Given this list of marker genes HOMER2, IL1A, XCL1, GATA3, CLEC7A, TRIM27, RIPK2, HDAC7, PTPRC, IRF4, FOXP3, CD28, LAPTM5, CD3E, DEFB124, HOMER3, MIR181C, STAT5A, GLMN, MAP3K7, CD4, CARD9, STOML2, IL1B, TRAF6, VTCN1, LILRB4, TNFAIP3, PDE4D, KAT5, PRKD2, CARD11, RUNX1, LAG3, PRKACA, TBX21, SPTBN1, MALT1, CD83, PRKCQ, PDE4B, CCR2, CD34, IL17F, SASH3, ANXA1 (annexin A1), TRAF2, STAT5B, CD86, VSIG4, ZFP36, GBP1 (guanylate binding protein 1, NCBI Gene Id 2633), NR1H4, HAVCR2, NAV3, SFTPD, IL20RB, CD80, GPR174, PNP, PRNP, RPS3 (NCBI Gene Id 6188), BTNL2, CR1, PLCG2, ABL1, EZR, here is a description of the gene set: The appearance of interleukin-2 due to biosynthesis or secretion following a cellular stimulus, resulting in an increase in its intracellular or extracellular levels. species: Homo sapiens Human Gene Set: GOBP_INTERLEUKIN_2_PRODUCTION